The following is a description of a gene set: species: Homo sapiens Pathway Definition from KEGG: (Protein+UB) -- 26S -> Peptide 26S proteasome-mediated protein degradation. Pathway ID: N01029. Pathway type: Reference. Pathway class: nt06460 Alzheimer disease. Human Gene Set: KEGG_MEDICUS_REFERENCE_26S_PROTEASOME_MEDIATED_PROTEIN_DEGRADATION, and this is the list of marker genes: PSMD7, RPS27A, PSMD11, PSMB3, PSMC1, ADRM1, PSMC3 (proteasome 26S subunit, ATPase 3), UBA52, PSMA4, PSMA3, PSMA5, PSMD13, PSMD4 (NCBI Gene Id 5710), PSMA2, PSMB6, PSMD6 (proteasome 26S subunit, non-ATPase 6), PSMB5, PSMD9, PSMA1, PSMC4, SEM1 (NCBI Gene Id 7979), PSMB4, PSMB7, PSMD2, PSMD14, PSMD8, PSMC6, PSMB2, PSMC2, PSMA8, UBC, PSMD12, PSMC5, PSMA7, PSMA6, PSMD3, PSMB1, UBB, PSMD1 (proteasome 26S subunit, non-ATPase 1)